Given this list of marker genes Slc27a2, here is a description of the gene set: Reactome Pathway: Alpha-oxidation of phytanate species: Mus musculus part of: Peroxisomal lipid metabolism This event has been computationally inferred from an event that has been demonstrated in another species.<p>The inference is based on the homology mapping from PANTHER. Briefly, reactions for which all involved PhysicalEntities (in input, output and catalyst) have a mapped orthologue/paralogue (for complexes at least 75% of components must have a mapping) are inferred to the other species. electronically inferred by orthology from the curated human pathway